The following is a description of a gene set: The regulated release of any steroid that acts as a hormone into the circulatory system. Mouse Gene Set: GOBP_STEROID_HORMONE_SECRETION species: Mus musculus, and this is the list of marker genes: Crh, Gdf9 (NCBI Gene Id 14566), Nrg1, Cry2, Dab2, Tac1, Retn, Spp1, Ptpn11, Crhr1, Wnk4, Agtr2, Galr1, Bmp6, Agtr1a (NCBI Gene Id 72294), Kcnq1, Kcnk9, Gal, Cyp2j5, Mfn2, Ren1, Cyp19a1, Selenom, Inhba, Ghrl, Pomc, Runx1, Tspo, Nkx3-1, Kdm5b, Agt, C1qtnf1, Fzd4, Cry1, Ecrg4